Given this list of marker genes CCL23, FPR3, FPR1, APP, FPR2, MT-RNR2, HEBP1, ANXA1, SAA1, here is a description of the gene set: Reactome Pathway: Formyl peptide receptors bind formyl peptides and many other ligands part of: Peptide ligand-binding receptors The formyl peptide receptor (FPR) was defined pharmacologically in 1976 as a high affinity binding site on the surface of neutrophils for the peptide N-formyl-methionine-leucine-phenylalanine (fMLF). FPR was cloned in 1990 and the cDNA used as a probe to identify two additional genes, FPRL1 and FPRL2. The three genes for a cluster on 19q13.3. All are coupled to the Gi family of G proteins. <br> All 3 receptors can be activated by formyl peptides but also display affinities for a range of structurally diverse ligands. studied in species Homo sapiens